Given this list of marker genes GSK3B, UBC, PARP6, UBE2I, ST3GAL1, PARP4, PARP8, UBB, PARP10, MOGS, ST6GALNAC3, PARP9, ST6GALNAC4, ST3GAL4, PRKCSH, GALNT1, ST3GAL3, MGAT1, UBA52, GANAB, ST6GALNAC2, GSK3A, SUMO1, PARP14, RPS27A, CANX, ST3GAL2, PARP16, ST6GAL1, here is a description of the gene set: Human Gene Set: REACTOME_TRANSLATION_OF_SARS_COV_1_STRUCTURAL_PROTEINS studied in species Homo sapiens Translation of Structural Proteins